The following is a description of a gene set: part of: Infection with Mycobacterium tuberculosis Mycobacterium tuberculosis (Mtb) encounters a vastly changed environment shortly after being internalized by macrophages. The compartment it resides in, the phagosome, is acidified and devoid of important metal ions and is flooded with reactive oxygen and nitrogen species. Steps will be soon taken by the macrophage to "mature" the phagosome with all kinds of lysosomal digestive enzymes. However, unlike most other bacteria species, Mtb has evolved solutions to each of these threats. As a last resort to a strong immune response, some bacteria will enter a dormant state (de Chastellier 2009, Flannagan et al. 2009). To what extent this is true is still unclear. Upon weakening of the immune defense, Mtb reawakens from its dormant state and starts to multiply inside the phagocyte. Reactome Pathway: Response of Mtb to phagocytosis studied in species Homo sapiens, and this is the list of marker genes: KPNA1, MAPK1, lprM, TRIM27 (NCBI Gene Id 5987), Rv3655c, eis, ENO1, ndkA, secA2, esxG, RAB5A, Rv3364c, ptpA, Rv3654c, lpdC, HGS, PPE2, UBA52, NOS2, esxH, sapM, VPS33B, RNF213, GSK3A, esxA, CORO1A, Rv1410c, PGK1, UBC, MAPK3, KPNB1, ATP6V1H, CTSG, lprG, SFPQ, RAB7A, RPS27A, UBB, DUSP16